The following is a description of a gene set: Mouse Gene Set: MIR_29B_3P studied in species Mus musculus Genes predicted to be targets of miRBase v22 microRNA mmu_miR_29b_3p in miRDB v6.0 with MirTarget v4 prediction scores > 80 (high confidence targets). from publication Chen Y, Wang X (PMID 31504780), and this is the list of marker genes: Nfat5, Nup160, Lin7a (lin-7 homolog A, crumbs cell polarity complex component), Fbn1, Cdk6, Crispld1, Trim63, Icos, Naa40, Gpr161, Purg, Hcn1, Fam167a, Dcx, Zmiz1, Proser1, Rfx7, Fscn1, Smtnl2, Hmgcs1, Rmnd5a, Elf2, Col27a1, Dnmt3a, Vash1, Eml6, Csrnp2, Col15a1, Ppic, Dpysl2 (NCBI Gene Id 12934), Slc4a7, Smim17, Zfp36l1, 0610030E20Rik, Gpr37, Ky, Zfp568, Pxdn, Slk, Eva1b, Eln, Syn3, Bmf, Gpx7, Col7a1, Elovl4, Tnrc18, Fstl1, Traf3, Rnpepl1, Adamts6, Slc43a2, Tet2, Ccdc28b, Hdac4, Arrdc3, Bach2, Igsf9b, Lpl, Dusp2, Efna5, Clock, Traf4, Npas3, Gpr82, Dpysl5, Ttc9, Mybl2, Adamts10, Pcdha9, Col3a1, Amot, Adamts7, Iffo1, Prkra, Pcdha6 (protocadherin alpha 6), Stard8, Ifi30, Uaca, Vegfa, Eps15, Tspan4, Ppm1d, Slc31a1, Rere, Slc19a3, Dlg2, Arf2, Smurf2, Iqschfp, Bak1, Pmp22, Adamts9, Mycn, Pdik1l, Ythdf1, Rnd3, Shroom2, Taf5, Kif26a, Atp1b4, Hrk (harakiri, BCL2 interacting protein (contains only BH3 domain)), Pcdha7, Hspg2, Dtwd2, Col5a1, Has3, Mex3b, Erc1, Timd2, Arpp19, Hmcn1, Trib2, Col4a5, Nasp, Ccnl2, Apc, Fam168b, Sh3bp5l, D630045J12Rik, Sp1, Gng12, Pcdha2, Erlin2, Col4a6, Fer, Kdm4b, Mark3, Nsd1, Sypl2, Tll1, Eomes, Mbtd1, Kcnip2, Zfp704, Rarb, Eif4e2, Bmt2, Jazf1, Arvcf, C1qtnf6, Zbtb47, Gpr156, Ccnyl1, Stx16, Adamts16, Pcdha8, Fbxw9, Adipor1, Atad2b, Ptbp3, Lysmd1, Adamts18, Pdgfa, Fubp1, Hbp1, Smpd3, Gpcpd1, Gtpbp2, Cd276 (CD276 antigen), Mtmr4, Nckap5, Aco1, Tfeb, Lif, Pcdhac1, Rev3l, Slc30a3, Slc25a3, Trafd1, Sgk1, Otub2, Col4a3, Kcna5, Col1a1, Jarid2, Mcl1, Il1rap, Sms, Pcdha12, Unc13b, Pi15, Kmt5c, Nktr, Kdm5b, Wdfy1, Adam12, Rexo1, Nrep, Tubb2a, Bltp3b, Xkr7, Sparc, Nap1l3, Asxl3, Atrn, Rnf19a, Pcdha4, Tet3, Klf4, Hapstr1, Ireb2, Col6a3, Ddx3x, Ythdf3, Sh3pxd2a, Senp1, Rab6b, Wdcp, Tmtc3, Col4a2, Rest, Sidt1, Morf4l2, Ppm1e, Adamts17, Tcf4, Foxj2, Nfia, Chfr, Usp37, Nav2, Mapkbp1, Wwtr1 (WW domain containing transcription regulator 1), Psma3, Hormad1, Kmt5a, Akt3, Lox, Rab30, Amer1, Map4k4, Fem1b, Klhl28, Or2ag2b, Ccser2, Zfx, Ubn1, Nkapd1, Fbxw7, Eml4, Ak3, Fam241a, Col5a3, Blm, Enho, Grip1, Pcgf3, Zmym2, Tfec, Dcun1d4, Nkiras2, Taf7, Ppp1r1c, Adamts2, Col19a1, Matn3, Dennd1b, Pik3r1 (phosphoinositide-3-kinase regulatory subunit 1), Pcsk5, Adam19 (NCBI Gene Id 11492), Ybx3, Dicer1, Mtfr2, Pcdha10, Palm, Pan2, Zfp282, Robo1, Fermt2, Col22a1, Zdhhc21, Dio2, Fras1, Samd4, Tpm1, Col25a1, Rapgefl1, Sppl2b, Zbtb5, Pcdha1, Stmn2, Dbt, Pcdha5, Entpd7, Tmem183a (NCBI Gene Id 75635), Tpk1 (NCBI Gene Id 29807), Calcr, Glis2, Wbp1l, Gxylt2, Igf1, Tet1, Pten, Hecw1, Nav1, Etv4, Abce1, Zfp91, Dnmt3b, Dynlt1b, N4bp2l1, Dgkd, Zbtb34, Gid8, Map6, Kdm2a, Nexmif, Col4a1, Morf4l1, Tlcd3b, Cpsf7, Serpinh1, Mxd1, Col5a2, Abcb6, Dpp3, Otud4, Ankrd13b, Zbtb10, Pgap2, Ric1, Zfp346, Ldlrap1, Dgkh, Chsy1, Carmil1, Tnfrsf1a, Pgap1, Mfap5, Col9a1, Natd1, Plp1, Cldn1, Pcdhac2, Pcdha11, Serpina1f, Col2a1, Pcdha3, Frat2, Col11a1, Sestd1, Atp2b4, Tarbp1, Edaradd, Camk4, Brwd3, Zfp512b, Tmem169, Mfap3, Eml5, Kif26b (kinesin family member 26B), Ppp1r3d, Akap5, Zfp36, Slc5a8, Col8a1, Narf